Given this list of marker genes TGFBR3, CTNND1, MIR503, MIR22, JCAD, MIR132, SLIT2, MIR2355 (NCBI Gene Id 100423036), MIR23A, HDAC9, CARD10, HDAC7, PIK3R3, MIR205, MIR146A, SPRED1, FGF2, ADTRP, ABL1, MIR497, THBS1, MIR885, MIR200C, TBXA2R, SRF, MIR126, GPLD1, HDAC5, MEOX2, MIR26A1, MIR483, MIR329-1, MIR361, STARD13, ANXA1 (annexin A1), GATA2, ITGB1, MIR487B, MIR206, PDCD10, ROBO1, CLEC14A, RHOA, HMOX1, CRIPTO, MIR10B, EGR3, MIR424, MIRLET7F1, PIK3C2A, MIR15A, MIR150, MIR199A1, MAP2K5, MMRN2, MIR196A1, MICALL1, MIR494, MIR320A, MIR27B, CIB1, MIR193A, MIR495, MIR29C, GREM1, AKT3, PLK2, EPHB4, ITGB1BP1, NOTCH1, MIA3, CDH5, MIR16-1, PTGS2, EFNB2, RHOJ, NR2E1, MIR221, FGFBP1, VEGFA, PACSIN2, MIR296, MIRLET7A1, MIR101-1, MIR410, NRP1, NR4A1, DLL4, KLF4, MMRN1, AKT1, MIR31 (microRNA 31), KDR, EHD4, MIR20A, MIR27A, MIR19B1 (NCBI Gene Id 406980), MIR10A, NUS1, SRPX2, FOXC2, MIR149 (microRNA 149), here is a description of the gene set: species: Homo sapiens Human Gene Set: GOBP_CELL_MIGRATION_INVOLVED_IN_SPROUTING_ANGIOGENESIS The orderly movement of endothelial cells into the extracellular matrix in order to form new blood vessels involved in sprouting angiogenesis.